Given this list of marker genes PPM1F, CDKL5, MYH10, FOLR2, KCNN1, RWDD2A, NHP2, FST, KLK11, GHR, MAPK11, GPR50, VSTM4, SLC46A3, JAG1, LOX, COL4A5 (collagen type IV alpha 5 chain), NECTIN1, HSD3B2, TNFRSF21, GPR12, PPY, LY6G6C, RBM17, ARHGAP22, STAT1, ACP3, CACNB2, GNGT1, HIPK2, CACNA1C, PICK1, TRPC2 (NCBI Gene Id 7221), SWAP70, LCN1, NECAB3, ATP2C2, TEAD1, CPSF6, LRIG2, GDF5, ERICH1, TYMP, PLPP3, KRT15, CCDC86, GPR162 (G protein-coupled receptor 162), IMPA2, HSD17B6, KL, HRG, PACRG, IFIT5, MYOD1, C15orf39, SPOCK2, PLXDC1, H1-4, CTRC, ZBTB22, HAO1, ALPI, SMPDL3A, HR, SPRR2C, CFAP20, SCNN1G, EPHB3, ZNF132, GNG12, PLA2G1B, LPL, PRKAR2A, RAB3A, ZNF202, LY6E, EYA2, AP4E1, LECT2, PPP3CA, TRPM2, PIK3CD, ABCA2, FAM149A, SKI, MRAS, MYH15, DLGAP4, CCDC57, ADCY2, CYBB, AGFG2, ATP10D (NCBI Gene Id 57205), DDX51, MALT1, ATP6V1G2, SLC10A1, TNNI1, PSKH1, CCL2, PTCH1, MCAT (malonyl-CoA-acyl carrier protein transacylase), C2, MAGI1, GRM3, CALB2, REG3A (regenerating family member 3 alpha), ITIH3, FZR1, MATN4, KLK13, CYP7B1, TMEM151B, ELANE, CLPS, CPVL, DUX4L8, NCF4, MGA, NAT2, GPRC5B, HEPH, GNRHR, BLK, DNAH17, TRPV6, PLEKHO2, RHOBTB2, GRAP, PTPRN, CYP2C18, DPF2, MYO9B, GPR37L1 (NCBI Gene Id 9283), ADAM12, RRH, DPF1, BRWD1, FABP3, VPS9D1, ITGB4, KIFAP3, P2RX5, ZNF536, NOP2, ATP2B3, STMN2, FZD2, BFSP2, FAM131B, KLF12 (NCBI Gene Id 82238), SENP5, CADPS, LORICRIN (loricrin cornified envelope precursor protein), MSR1, TAT, DNASE1L2, TFAP2B, TXNRD2, ZNF821, DSC3, GAS6, ABCA12, SF3A3, COLGALT2, PLD2, ANGPT1, AATK, CYP4F12, CDK20, CRYGD, SULT2B1, PLCB4, CPNE1, SAMM50, GJA1, IRF8, WSCD2, PLXNB3, SCN2B, GAST, CHM, NKX2-5, APOA4, PLLP, CYP17A1, ELK3, HOXD13, MYO7A, TMPRSS15, TAF13, FCGBP, COL15A1, GYPB, BBIP1, TRAK2, DNAJB12, here is a description of the gene set: from publication Gattinoni L, Lugli E, Ji Y, Pos Z, Paulos CM, Quigley MF, Almeida JR, Gostick E, Yu Z, Carpenito C, Wang E, Douek DC, Price DA, June CH, Marincola FM, Roederer M, Restifo NP (PMID 21926977) studied in species Homo sapiens Human Gene Set: GSE23321_CENTRAL_MEMORY_VS_NAIVE_CD8_TCELL_DN An early-differentiated CD8+ memory T cell subset with stem cell-like properties (TSCM) can be identified within the naïve-like T cell population by the expression of CD95/Fas. Based on experiments including exon- and gene-level expression analysis, we provide evidence that this subset of antigen-specific cells represents an early precursor of conventional central (TCM) and effector (TEM) memory CD8+ T cells with enhanced self-renewal capacity and proliferative potential. We identified genes differentially expressed between major T cell subsets defined along with memory T cell commitment. Based on the analysis of these genes, CD95+ naïve T cells (TSCM) cluster closer to the CD8+ T memory compartment than to classical (CD95-) naïve T (TN) cells, and display an intermittent phenotype between classical TN and TCM cells in terms of all major T cell differentiation markers analyzed. Genes down-regulated in CD8 T cells: central memory versus naïve.